Given this list of marker genes Gja1, Casp3, Gm13394, Slc66a3, Vamp5, Klra1 (killer cell lectin-like receptor, subfamily A, member 1), Spp1, Apcdd1 (NCBI Gene Id 494504), Rasa1 (RAS p21 protein activator 1), Ctsl, Rgs16, Sema7a, Nupr1, Tgfbi (NCBI Gene Id 21810), Plp2, Fut8, Wwtr1, Ssna1, Areg, Capg, Tspo, Rab7, Laptm4b, Clic1, Csrp2 (cysteine and glycine-rich protein 2), Angptl2, Upp1, Acot7, Sema5a, Serpina1a, Crabp1, Ngef, Sptssa, Pmf1, Itgb7, Gdnf, Pold4, Selenof, Kcnn4, Gpc1, Hmga2, Ank, Ggct, Kitl, Tmsb4x, Klra4, Gadd45a, Cytip, Itga6, Pdgfa, Cdkn1a, Zfp706, Cd9, Evi2a, Ccnd1, Rad51, Fxyd5, Eif2s1, Bbln, Rhox5, Klra13-ps, Pclaf, Psmb5, Tes, here is a description of the gene set: Mouse Gene Set: CHIARADONNA_NEOPLASTIC_TRANSFORMATION_KRAS_CDC25_UP Genes up-regulated in NIH3T3 cells (fibroblasts) transformed by activated KRAS vs those reverted to normal cells upon over-expression of a dominant negative form of CDC25. from publication Chiaradonna F, Sacco E, Manzoni R, Giorgio M, Vanoni M, Alberghina L (PMID 16607279) Mutational activation of ras genes is required for the onset and maintenance of different malignancies. Here we show, using a combination of molecular physiology, nutritional perturbations and transcriptional profiling, that full penetrance of phenotypes related to oncogenic Ras activation, including the shift of carbon metabolism towards fermentation and upregulation of key cell cycle regulators, is dependent upon glucose availability. These responses are induced by Ras activation, being specifically reverted by downregulation of the Ras pathway obtained through the expression of a dominant-negative Ras-specific guanine nucleotide exchange protein. Our data allow to link directly to ras activation the alteration in energy metabolism of cancer cells, their fragility towards glucose shortage and ensuing apoptotic death. studied in species Mus musculus